The following is a description of a gene set: Binding to a syntaxin-1 SNAP receptor. species: Mus musculus Mouse Gene Set: GOMF_SYNTAXIN_1_BINDING, and this is the list of marker genes: Unc13a, Snap25, Vamp2, Stxbp5, Vamp3, Slc6a4, Nsf, Cplx2, Stxbp3, Stxbp2, Unc13b, Rnf40, Syt4, Stxbp1, Cplx1, Lrrk2, Dapk1, Syt1, Myo5a, Unc13c, Syp, Prrt2